Given this list of marker genes UCHL1, FEZ1, MFAP4, TRIM9, MSLN, NR2F1, TRAM1L1, TUBB2A, TMSB4X, SERF1A, OLIG3, DMRT2, CRABP1, PCP4, NRARP, VCAM1, SCG3, TGFBI, CLEC1B (C-type lectin domain family 1 member B), WFDC1, RGS2, EN2 (NCBI Gene Id 8311), YJU2, NREP, MEOX2, HOXD12, CP, CRABP2, TUBB3, VTN, SPSB4, DLL3, NNAT, HDDC3 (HD domain containing 3), MFAP2, TCF15, IGDCC3, here is a description of the gene set: Genes down-regulated in 9.5 days post coitus (dpc) embryos with COMMD1 knockout compared to normal 9.5 dpc embryos. Human Gene Set: VANDESLUIS_COMMD1_TARGETS_GROUP_3_DN studied in species Mus musculus COMMD1 (previously known as MURR1) belongs to a novel family of proteins termed the copper metabolism gene MURR1 domain (COMMD) family. The 10 COMMD family members are well conserved between vertebrates, but the functions of most of the COMMD proteins are unknown. We recently established that COMMD1 is associated with the hepatic copper overload disorder copper toxicosis in Bedlington terriers. Recent in vitro studies indicate that COMMD1 has multiple functions, including sodium transport and NF-kappaB signaling. To elucidate the function of Commd1 in vivo, we generated homozygous Commd1 null (Commd1(-/-)) mice. Commd1(-/-) embryos died in utero between 9.5 and 10.5 days postcoitum (dpc), their development was generally retarded, and placenta vascularization was absent. Microarray analysis identified transcriptional upregulation of hypoxia-inducible factor 1 (HIF-1) target genes in 9.5-dpc Commd1(-/-) embryos compared to normal embryos, a feature that was associated with increased Hif-1alpha stability. Consistent with these observations, COMMD1 physically associates with HIF-1alpha and inhibits HIF-1alpha stability and HIF-1 transactivation in vitro. Thus, this study identifies COMMD1 as a novel regulator of HIF-1 activity and shows that Commd1 deficiency in mice leads to embryonic lethality associated with dysregulated placenta vascularization. from publication van de Sluis B, Muller P, Duran K, Chen A, Groot AJ, Klomp LW, Liu PP, Wijmenga C (PMID 17371845)